The following is a description of a gene set: species: Mus musculus A specialized eukaryotic organelle that consists of a filiform extrusion of the cell surface and of some cytoplasmic parts. Each cilium is largely bounded by an extrusion of the cytoplasmic (plasma) membrane, and contains a regular longitudinal array of microtubules, anchored to a basal body. Mouse Gene Set: GOCC_CILIUM, and this is the list of marker genes: Kif7, Traf3ip1, Cfap157, Jade1, Prkaca, Tbc1d21, Cc2d2a (coiled-coil and C2 domain containing 2A), Slc24a4, Cimip2b, Gnat3, Dydc1, Ccdc38, Spmip9, Spmip6, Cep131, Nxnl1 (NCBI Gene Id 77196), Fam149b, Kif17, Ofd1, Tbcc, Egfr, C2cd3, Spa17, Psen2, Ct55, Map1lc3b, Pkm, Cngb3, Ak2, Spmip8, Hydin, Ssna1, Dnaaf1, Kiss1r, Trpv3, Galr3, Lztfl1, Sufu, Stag1, Dnah5, Mapk15, Lyar (NCBI Gene Id 17089), Slirp, Dusp3, Poc1a, Adgb, Cnga3, Catsper4, Cibar2, Ttll1, Ttll8 (tubulin tyrosine ligase-like family, member 8), Pcdh15 (protocadherin 15), Ak7, Prkci, Drd5, Pcdh11x, Cacna1f, Disc1, Pfkm, Cntrl, Ak8, Ankmy2, Qrich2, Cnga1, Tpgs1, Kif5c, Vps37c, Vcp, Pik3r4, Cfap144, Cfap36, Cd24a, Tsga10ip, Ccdc39, Alpk1, Kcnu1, Pkd1l1 (polycystic kidney disease 1 like 1), Gnat2, Myo7a, Dync2h1, Saxo1, Odad1, Cplane1, Ttll13, Hif1a, Mapre1, Lrrc23, Cep83, Septin2, Rttn, Odad4, Tapt1, Rsph3b, Ssxb10, Abhd2, Guca1a, Omp, Cc2d2b, Sptbn5, Pcdhb16, Myrip, Togaram1, Pde6b, B9d1, Smo, Cfap161, Spmip10, Dnaaf5, Atp1b3, Ift80, Tuba1c, Spata4, Cfap126, Spag16, Iqub, Spag8, Umod, Cep72, Cep44 (centrosomal protein 44), Mapk1, Gpr83, Cep152, Spata33, Poc5, Dnah10, Entr1, Slc26a6, Glis2, Ccdc81, Erich3, Rab34 (RAB34, member RAS oncogene family), Tsc1, Ptchd3, Tekt4, B9d2, App, Dnai4, Smad3, Ttc29, Opn3, Rabl2, Togaram2, Ccdc65, Slc25a31, Rp1, Cys1, Iqce, Adam15, Fbxw8, Eno4, Tctn1, Catsper1, Iqcd, Ift22, Prkar2b, Gnai2 (G protein subunit alpha i2), Mark4, Vps13a, Rpgrip1, Nme5, Pkd2, Pacsin2, Ttll10, Flcn, Pde6a, Cdc45, Arl13a, Cadps2, Evi2a, Cfap57, Grk3, Snrnp200, Smad6, Cimip2c, Wdr35, Bbs12, 2700049A03Rik, Aurka, Fuz, Dynlt2b, Cfap221, Septin7, Psmb4, Cfap77, Rilpl1, Arl2, Rcvrn, Adcy6, Cimap3, Qrfpr, Ccdc178, Mns1, Evc2, Spata6, Cep250, Ropn1l, Kif2a, Mlf1, Katnip, Clxn, Fbf1, Kctd10, Catsperd, Rilpl2, Cep164, Bbs10, Kif11, Hoatz, Ckap2, Cfap210, Ift20, Sqstm1 (NCBI Gene Id 18412), Spef1l, Tubb4a, Dnai1, Stoml3 (NCBI Gene Id 229277), Myoc, Hspd1, Txndc2, Akt1, Kifap3, Gas8, Wdr54, Usp48, Pde6h, Ush1c, Septin4, Mical1, Catsper3, Adcy10, Catsperg2, Cfap58, Slc26a8, Shank3, Ift74, Agbl4, Tedc2, Kif3b, Pqbp1, Wrap73, Tchp, Tmem262, Akap9, Map1b, Irgc, Mok, Phlpp2, Sag, Mks1, Cfap119, Drc1, Cdkn1b, Prkar2a, Rpgrip1l, Dnah9, Ccdc14, Trpv4, Tbc1d32, Wdr19, Bbs5, Nphp4, Dzip1, Tmem107, Rsph14, Ddx6, Tektip1, Ahi1, Pex6, Fzd6, Odad2, Catspere2, Cfap300, Chrm2, Npr2, Crocc, Dnaaf2, Klc3, Ift27, Wbp2nl, Cep170, Adora1, Ribc1, Rp2, Cetn2, Ttbk2, Tubgcp5, Cfap276, Rab6a, Timd2, Rsph1, Enkur, Magi2, Ccdc42, Tulp1, Havcr1, Unc119b, Smg6, Stx3, Bag3, Prkaa2, Cby1, Cfap298, Rab15, Gapdhs, Dctn1, Cfap65, Ttll2, Iqcg, Arfgef2, Il4i1, Txndc15, Mxra8, Tubd1, Notch2, Dnai3, Septin9, Cd52, Dynlt4, Odf2, Cep162, Cib2, Tcp11, Kmt5b, Kif3a, Akap4, Ift81, Ptgs1, Cyld, Ace, Adrb2, Tmem80, Sel1l2, Cerkl, Gle1, Zmynd12, Catsper2, Rabep2, Gli3, Gnai1, Rab11fip3, Dynll1, Iqca1, Lrrc51, Catsperb, Lyzl4, Fzd4, Bbs9, Tas2r108, Ift52, Map2k1 (mitogen-activated protein kinase kinase 1), Psmd10 (NCBI Gene Id 54172), Acaa2, Prph2, Bsg, Dnai2, Ssxb1, Ush2a, Hras, Erc1, Tedc1, Slc9c1 (solute carrier family 9, subfamily C (Na+-transporting carboxylic acid decarboxylase), member 1), Psmc4, Marcks, Prkcz, Tmem232, Ctsh, Fan1, Bbip1, Cep128, Cnga2, Adcy9, Rpap2, Sstr3, Spag1, Pcdhb22, Pacrg, Pierce1, Odf1, Agtpbp1, Tsga10, Acta2, Arl2bp, Anks3, Grhl3, Calcr, Dld, Gstm5 (NCBI Gene Id 14866), Cfap141, Ssxb8, Gas2l2, Abca4, Aldoart1, Gli1, Dnah11, Rac1, Spag17, Lrrc46, Cep15, Vcan, Ccdc120, Cfap52, Invs, Cimip1, Efcab9, Pjvk, Syne2 (NCBI Gene Id 630548), Haus3, Ruvbl1, Cntrob, Irs1, Prkacb, Ptpn23, Oxct2b, Cfap61, Nek2, Rpap3, Ift122, Ssxb13, Dnah7b, Creb1, Dnaaf11, Dnaaf4, Il10ra, Rab10, Haus7, Pmm2, Nphp1, Nubp1 (nucleotide binding protein 1), Psma6, Ctnnb1, Ssx2ip, Tbc1d30, Dnah2, Usp9x, Ift56, Timd6, Efhc2, Eps15, Pmfbp1, Tekt2, Usp26, Slc22a14, 1700012B09Rik, Evc, Hyal3, Arhgap35, Hipk1, Cfap45, Atp2b2, Vhl, Tubg1, Cul3, Phyh, Cabcoco1, Gngt1, Ccdc40, Tssk3, Rnf38, Nek5, Ptk2, Aldoa, Cimip2a, Pgr15l, Dnah8, Kif20b, Spata7, Cilk1, Fscb, Cdk20, Cep104, Met, Atp1a4, Sntn, Ppp4r4, Pttg1, Clcn4, Mapk3, Cfap44, Tmem218, Ssxb3, Gnb1, Spag5 (NCBI Gene Id 54141), Ttc21b, Tomm20, Tmem249, Nubp2, Cfap68, Dis3l, Tas2r120, Rd3, Spmip11, Rsph4a, Dnah1 (dynein, axonemal, heavy chain 1), Htr6, Txndc8, Pde6g, Tmem237, Ccr6, Gpr19, Defb37, Gk2, Dync1i2, Mosmo, Pgk2, Mcm2, Kif27, Mapt, Cfap410, Ift46, Nmur1, Pgam1, Pskh1, Impg1, Psme3 (proteaseome (prosome, macropain) activator subunit 3 (PA28 gamma, Ki)), Lyzl6, Pramel1, Crb1, Prcd (photoreceptor disc component), Atg14, Spice1, Klc2, Ccdc68, Pip4k2a, Cfap74, Dnah7c, Lrrc56, Zfp330, Elmod1, Micall1, Cfap54, Cep19, Fhad1, Ppp3cc, Mroh2b, Cdk5rap2, Mme, Tspear, Klc1, Rsph9, Dnah12, Rsl1d1, Ceacam1 (NCBI Gene Id 26365), Prom2, Pcare, Kif5b, Ptprk, Ran, Ttll7, Fank1, Gucy2e, Cav1, Cfap100, Pdgfra, Dnal1, Oaz3, Spmip5, Atg7, Cetn4, Nphp3, Ccdc103, Ffar4, Macir, Myo5a, Hdac6, Sclt1, Cep126, Prkca, Grk2, Adcy5, Scnn1a, Mertk, Dync2li1, Opn5, Prom1, Pdc, Cep290, Ambra1, Ccdc172, Utrn, Spata3, Camsap3, Saxo2, Cdkl5, Dnai7, Pkd2l1, Lca5, Ssxb15, Rabl6, Cfap107, Dynlt2a1, Cfap43, Cdh23, Cfap91, Prlhr, D630045J12Rik, Spaca9, Mapkapk2, Shank2, Slco6c1, Tmem231, Kcnq1, Dynll2, Daw1, Fhdc1, Ift25, Cfap73, Dnali1, Ppid, Akap14, Gucy2f, Grxcr1, Armc9, Lpar3, Arl3, Fsip1, Rho, Pde1c, Inpp5e (inositol polyphosphate-5-phosphatase E), Ehd3, Ace2, Plekhb1, Prkaa1, Ccdc113, Actl7a, Ropn1, Dnah14 (dynein, axonemal, heavy chain 14), Tgfbr1, Iftap, Brwd1, Vdac2, Rilp, Atf3, Dync2i2, Fbxl13, Tektl1, Nup42, Ppp2r3c, Kif19a, Cetn1, Odad3, Ift57, Npy2r, Akap3, Strc, Rp1l1, Pkhd1, Cbl, Sting1, Spata19, Bbof1, Spag4, Rrm1, Hyls1, Ttll6, Agbl2, Rsph6a, Pafah1b1, Rap1a, Stard10, Cimap1b, Enkd1, Axdnd1, Atp1a1, Ldha, Camsap2, Kncn, Slc26a3, Sdccag8, Gucy2d, Nme3, Nek8, Marchf7, Prph, Spaca3, Sphk1, Cnga4, Tcea2, Myo3b, Snap29, Pde4c, Defb1, Cfap206, Tssk1, Topors, Abcc4, Ccdc34, Spef1, Nfe2l2, Ccdc88a, Atp1b1, Braf, Mapkap1, Dnah6, Cfap96, Luzp1, Cep20, Daam1, Cibar1, Ccsap, Ccdc96, Cfap47, Hvcn1, Iqcb1, Dnah3, Smad7, Lrrk2, Ift172, Nup85, Pde1a, Hnf1a, Ccdc181, Pdzd7, Efhb, Ssxa1 (NCBI Gene Id 385338), Pola2 (NCBI Gene Id 18969), Atxn10, Sord, Ccdc153, Rrp7a, Rpgr, Arl13b, Necab1 (N-terminal EF-hand calcium binding protein 1), Ppp3r2 (protein phosphatase 3, regulatory subunit B, alpha isoform (calcineurin B, type II)), Dapk3, Cask (NCBI Gene Id 236691), Odf4, Smad4, Adcy3, Ccdc66, Tacr2, Dnhd1, Catsperz (NCBI Gene Id 77926), Anxa1, Pkd1, Ttc8, Mdm1, Efhc1, Dnah7a, Dnal4, Gpr37l1, Ubxn10, Atg16l1, Ssxb6, C130074G19Rik, Cfap69, Cct8, Dnajb13, Adgrv1, Ssxb5, Pdcl, Cenpf, Ssxb16, Pierce2, Ift70b, Arr3, Best2 (bestrophin 2), Dzip1l, Odf2l, Cep350, Gabarapl1, Bub1b, Lrrc45, Gnat1, Ckap2l, Cdhr1, Tssk4, Psmb7, Gpr161, Ift70a1, P2ry1, Spef2, C2cd6, Ldhc, Tmem17, Nherf1, Anks6, Ush1g (NCBI Gene Id 217309), Galr2, Calm1, Garin2, Gnai3, Ift70a2, Opn1mw, Cimip4, Prkar1a, Mkks, Wdpcp, Cplane2 (ciliogenesis and planar polarity effector 2), Cabyr, Gli2, Cabs1, Fam161a, Bbs7, Efcab7, Bbs1, Tcte1, Map1a (NCBI Gene Id 99114), 4930505A04Rik, Timd5, Drd2, Cc2d1a, Cep295nl, Opn1sw, Tcp11x2, Cfap251, Tbx3, Dlg5, Spmip4, Ocrl, Cfap53, Tekt1, Ak1, Cngb1, Bmp2, Septin6, Prpf6, Rsph3a, Nin (NCBI Gene Id 73198), Cep68, Psen1, Atg5, Ttll3, Ccdc61, Ift43, Bcl3, Akt3, Ssxb14, Kcnf1, Ttll5, Tmem67, Hsp90aa1, Drd1, Cimap1a, Tekt3, Catsperg1, Gpr157, Efcab6, Naxe, Ro60, Ttll4, Efcab2, Ift88, Cfap418, Kif5a, Cfap70, Tacr3, Cfap90, Nedd9, Drc3, Cdkl1, Sema4d, Ttll11, Mchr1, Tub, Rapgef4, Dync2i1, Fsip2, Gabarap, Nek4 (NCBI Gene Id 23955), Pcm1, Rab27a, Gpr88, Stk11, Ccp110, Cfap95, Poc1b, Ano2, Arl6, Tulp2, Spag6l, Nme8, Cspp1, Tbc1d31, Ccdc63, Cep41, Tacr1, Catspere1, Septin12, Cenpj, Tubb4b, Nme7 (NCBI Gene Id 338485), Rdh11, Tctn2, Tmem138, Spata18, Ruvbl2, Rab8a, Ribc2, Tbc1d7, Guca1b, Dcdc2c, Septin10, Cyrib, Tppp2, Inha, Abcc3, Cdk10, Cdc14a, Wdr11, Whrn, Mak, Tuba1b, Drc7, Ttll9, Tuba3a, Tmem216, Slc9b1, Slc9b2, Nedd1, Spag6, Cst11, Dcdc2a, Atp2b4, Atp6v1d, Ulk4 (unc-51-like kinase 4), Cep89, Lca5l, Tubgcp2, Cetn3, Cltb, Ajm1, Saxo4, Tekt5, Cluap1, Ptch1, Tuba1a, Cfap20, Alms1, Bbs2, Rab6b, Dusp21, Ttc23, Pcnt, Kif9, Intu, Flacc1, Tssk6, Ift140, Dnah17, Npffr1, Ezr, Rab28, Cep78, Gpi1, Ano10, Kcnj10, Elmod3, Csnk1a1, Grk1, Rom1, Tulp3, Bbs4, S100b (NCBI Gene Id 20203), Tiam1, Spaca5 (sperm acrosome associated 5), Ehd1, Morn5, Cct4